Given this list of marker genes Vps35, Nedd9, Mtmr2, Ckap5, Zmynd8, Ins1, Itpka, Ins2, Igf1r, Zfp804a (zinc finger protein 804A), Insr, Fcgr2b, Homer1, Cttn, Pick1, Itga3, Cntnap2, Tanc1, Grin2b, App, Abhd17b, Trem2, Prnp, Grin1, Apoe, Fyn, Cfl1, Abl2, here is a description of the gene set: species: Mus musculus The organization process that preserves a dendritic spine in a stable functional or structural state. A dendritic spine is a specialized protrusion from a neuronal dendrite and is involved in synaptic transmission. Mouse Gene Set: GOBP_DENDRITIC_SPINE_MAINTENANCE